Given this list of marker genes AFG3L2, MAL, COMMD6, NDUFA4, QPRT, LIMCH1, NOP10, MT-RNR1, SNRPN, VDAC1, CLINT1, ZC3H13, MRPL33, AHNAK, MT-CO2, COX6B1, VAMP8, OST4, SMIM24, MT-CO1, TFDP2, LHX1, ATP5MK (ATP synthase membrane subunit k), RBM47, ATP5IF1, AIF1L, TMEM72 (transmembrane protein 72), KNOP1, SELENOP, ATP5F1E, GCC2, SCUBE3, CYS1, CD24, TSTD1, CLCN5, KNG1, HOXB3, CYCS, GPRC5B, KIF3B, AHCYL1, ERBB2 (NCBI Gene Id 2064), KCNJ15, SCIN, HNF1A-AS1, PTBP3, ATP1A1, GATA3, QKI, MT-CO3, TGOLN2, RALBP1, YTHDC1, SLC25A5, MST1L, ATP6V1F, ANXA11, MFHAS1, CCDC198, TMCO1, PTH1R, COX4I1, LLGL2, NDUFA13, NDUFA3, SERPINF2, SAT1, S100A13, DECR1, SERF2, ATP5PD, FRMD4A, COBLL1, COL6A1, YWHAB, ARSD, NEDD4L, ADAMTS9, CDH16, NEAT1, NPNT, MITF, ATP5MG, MT-ND3, CAMK2N1, TMBIM6, ERBB4, ATP1B3, COL18A1, NDUFB10, ECI1 (NCBI Gene Id 1632), COX20, PTPRF, KIF12, PLEKHA5, COPS9, MST1P2, EMX1, NDUFA2, COPS6, CHCHD10, TMEM52B, FKBP2, NDUFA10, ANK3, COX5A, LMAN2, NSRP1, ZNF503, MPC1, NDUFA1, POLR2L, KRT19, COX7B, PSAP, PHLDB1, IGFBP7, TMEM245, SDC4, NFE2L2, HOXA9, ATP5ME, COX8A, RNPC3, ROMO1, HIPK2, VAV3, LAMB1, DSTN, SARAF, WFDC2, HSP90AA1, LAMTOR5, ITM2C, ARL4C, DAZAP2, GSTM3 (glutathione S-transferase mu 3), SUCLG1, COX6C, IVNS1ABP, PLEKHJ1, RPL36AL, KCNJ16, DCDC2, PTPN13, HSD11B2, LRPAP1, BTG1, CA12, COX5B, TFCP2L1, PHGDH, NDUFB9, RGL3, FXYD2, SNHG14, TMEM213, TRIM56, SOD1, FAM171A1, HOXD9, ZNHIT1, NDUFC1, PDHA1, JADE1, S100A6, RAB3IP (NCBI Gene Id 64325), HOXD8, TMED4, BEX2, ACADVL, COX7A2, IGFBP3, KCNJ1, GALNT11, TMEM59, MRPS6, SEC62, ZMAT2, MICOS13, ATP5F1B, WSB1, NDUFA6, MECOM, TCEAL4, PFKL (phosphofructokinase, liver type), NDUFB7, ETFB, ATP6V0B, TMA7, COL1A2, MUC1, UQCR10, MICOS10, APLP2, PTGR1, MYO10, MPHOSPH8, PTTG1IP, UBE2G2, NDUFA5, CTDSPL, NDUFB2, PAWR, NPC2, UQCRQ (ubiquinol-cytochrome c reductase complex III subunit VII), MALAT1, ATP5MC3, DEFB1, NDRG1, FERMT2, MGST3, ATP1B1, GLS, KRT8 (NCBI Gene Id 90177), PLXNB1, CHMP2A, ITM2B, SLC8A1, LDHB, ADD3, ATP5F1A, UQCRB (NCBI Gene Id 7381), TTC14, SEC61G, CYB5A, ATP5MC1, PNKD, MTURN, UQCRFS1, ATP6V0E1, HOXB-AS3, LRRFIP1, NIPSNAP2, MPC2, MYO6, ARHGAP24, NDUFB1, ATP6AP2, MRPS18B, COX6A1, CA2, WNK1, PEBP1, DNASE1, HIGD2A, COA3, NUDT4, MT-ND6, CISD1, SULT1C2, GSTK1, PRMT2, PIK3R1, CYC1, UQCR11, CLCNKB, ABLIM1, EPCAM, ATP6V1B1, EMX2, RTN4, POU3F3, TRIM2, RPS4Y1, COX7C, here is a description of the gene set: species: Homo sapiens Human Gene Set: MENON_FETAL_KIDNEY_8_CONNECTING_TUBULE_CELLS from publication Menon R, Otto EA, Kokoruda A, Zhou J, Zhang Z, Yoon E, Chen YC, Troyanskaya O, Spence JR, Kretzler M, Cebrián C (PMID 30166318)